The following is a description of a gene set: studied in species Mus musculus A ribonucleoprotein complex that contains a precursor small nucleolar RNA (pre-snoRNA) and associated proteins, and forms during small nucleolar ribonucleoprotein complex (snoRNP) assembly. Pre-snoRNP complexes may contain proteins not found in the corresponding mature snoRNP complexes. Mouse Gene Set: GOCC_PRE_SNORNP_COMPLEX, and this is the list of marker genes: Nop56, Nufip1, Taf9, Znhit3, Nop58, Pih1d1, Znhit6